The following is a description of a gene set: Adaptive Immune System Mouse Gene Set: REACTOME_ADAPTIVE_IMMUNE_SYSTEM studied in species Mus musculus, and this is the list of marker genes: Cd300c, Calr (calreticulin), Cd40, Stim1, Psmd11, H2-M10.2, Pak1, Psma4 (NCBI Gene Id 26441), Cd274, H2-DMa, Psmd6, Igkv2-137, Spsb1, Smurf2, Klc4, Kif13b, Kif3c, Ube3c, Rela, Treml1, Kif1c, Npdc1, Ppl, Ubr1, Fbxl13, Plcg2, Hecw2, Pik3cd, Tubb6, Tapbp, Lat, Icam5 (NCBI Gene Id 15898), Rnf138 (NCBI Gene Id 80618), Psmd13, Igll1, Kif21b, Ighv6-6, Siah1a, Rnf6, Ighv5-17, Igkv1-117, Rbck1, Herc4, H2-M10.4, Itgb2, Hectd3, Klhl41, Ptpn6, Ighv12-3, H2-M10.1, Psmd8, Psmc2, Prkcb, Cdc26, Inpp5d, Rbx1, Tuba1a, Trim71, Cul2, Crtam, Lrr1, Rlim (ring finger protein, LIM domain interacting), Psmc5, Rab7, Fbxl21, Kif2a, Ube2d3, Socs3, Fbxo6, Trbv15, Ighv5-9, Igkv1-132, Ccnf (NCBI Gene Id 12449), Fbxo7, Ppp3r1, Spsb4, Fbxo44, Cd300a, Actr1b, Nfkbib, Cxadr, Sec24d, Map3k8, Dtx3l, Rchy1, Klc3, Trim21, Ltn1, Ube3b, Ap2s1 (adaptor-related protein complex 2, sigma 1 subunit), Klhl21, Fbxo27, Ighv5-12-4, H2-M11, Psmb10, Cd226, Rnf213, Psmb3, Cd3g (NCBI Gene Id 12502), Asb5, Hspa5, Iglc2, H2-T10, Fbxw17, Kif9, Tuba1b, Raf1, Cdc20, Itpr1, Ighv8-2, Igkv1-99, Asb14, Fbxo22, Klrk1, Asb13, Asb9, Akt1, Adrm1, Ppp3cb, Ctss, Psmb8, Siglech, Cd81, Csk, Vhl, Pik3r6, Lrsam1, Fkbp1a, Clta, Tyrobp, Kif3a, Klhl25, Actr1a (NCBI Gene Id 54130), Cd22, Klhl22, Osbpl1a, Igkv1-110, Siglec1, Psma6, Psma5, Ifitm1, Ighv3-6, Map3k14, Ighv8-8, Sec31a, Trav19, Dctn4, Rnf220, Ncf1, Spsb2 (NCBI Gene Id 14794), Psme2, Anapc1, Rnf126, Cd79a, Keap1, Mrc2, Mapkap1, Pten, Map3k7, Kif23, Klhl20, Potefam3d, Fbxo10, H2-M3, Mylip, Ap1g1 (NCBI Gene Id 52301), Ighv6-3, Asb10, Kir3dl1, Atg7, Traf7, Xdh, Fyn, Grb2, Tubal3, Sec22b, Psme2b, Them4, Ctsd, Psmd2 (NCBI Gene Id 77434), Ctso (NCBI Gene Id 99547), Kif19a, Fbxl14, Tubb2a, Ctsf, Igkv20-101-2, Ctsb, Ighv8-11, H2-Q7, Ap2m1, Ighv6-4, Btnl9, Itgb1, Psmb7, Asb4, Siglece, Kif20b, Prkaca, Cdc42, Ap1m1, Lmo7, Ap1b1, Pdcd1, Cybb, Traf6, Unkl, Herc1, Cd101, Asb18, Ppp2r1a, Asb16, Rapgef4, Anapc13, Hace1, Asb6, Ube2v2, Psmd14, Igkv18-36, Mkrn1, Igkv1-122, Igkv2-112, Col3a1, Fbxo31, Tuba8, Igkv8-21, Card11, Itk, Kif1a, Ncf4, Trim32, Psmc3, Trim41, Btnl2 (NCBI Gene Id 632007), Ubox5, Wsb1, Ptpn22, Calm2 (calmodulin 2), H2-Ea, Klhl11, Bcap31, Mib2, Fbxo17, Igkv1-135, Btbd1, Ube2s, Yes1, Lcp2, Rel, Huwe1, Cul1, Tubb2b, Pja1, Ap2a2, Btn2a2, H2-K1, Lyn, Ighv5-2, Pja2, Lnpep, Rasgrp1, Ppp2r5b, Kctd6, Kbtbd7, Rap1b (NCBI Gene Id 72733), Raet1e, Asb12, Ifi30, Igkv1-35, Lgmn, Sos1, Fbxl8 (NCBI Gene Id 50788), Trac, Fbxo9, Dynll1, Asb17, Treml2, Ubc, Cul3, Ube2e3, Ube2b, Potefam3c (NCBI Gene Id 670593), Pdcd1lg2, Fzr1, Rap1a, Rap1gap, Ighv5-9-1, Cd96, Rbbp6, Jaml, Socs1, Kif5b, Dctn1, Ppp2ca, Igkv17-121, Dapp1, Tap1, Cd207, Calm1, Arel1 (apoptosis resistant E3 ubiquitin protein ligase 1), Ube2w, Fbxw9, Kif21a, Icam4, H2-Eb2, Fbxo32, Capza2, Sptbn2, Psma1, Dync1i2, Rnf4, Itgb7, Lair1, Prkn, Fbxl19, Ube2j1, Gan, Ap1m2, Fbxo2, Fyb1, Cul7, Itpr3, Anapc5, Psmc1, Klhl2, H2-Q2, Ighv3-3, Cd8b1, Ctla4, Dync1li1, Kras, Kctd7 (potassium channel tetramerisation domain containing 7), Cd300lb, Fbxo4, Dynll2, Rac1, Kif28, Ighv8-13, H2-T22, Rapgef3, Ifitm3, Cd300e, Fbxw5, Tuba3a, Mrc1, Ap2a1, Rnf19a, Ap1s2, Uba7, Sftpd, Kif3b, Psma3, Anapc11, Rnf111, Ighv7-3, Ppp3ca, Trem2, Col2a1, Ikbkb, Tab2, Fbxw10, Akt3, Ctsl, Zap70, Cd8a, Trim69, Kif11, Ighv5-12, Anapc4, Blnk, Thop1, Vcam1, H2-M10.3, Prkcq, Psma2, Traip, Rnf130, Erap1, Ube2l3, Fbxw2, Igkv16-104 (immunoglobulin kappa variable 16-104), Ppp2r5c, Pvr, Pik3r1, Pik3r2, Kifc1, Dctn3, Cd86, Trim36, Pik3ap1, Col17a1, Col1a1, Psmb2, Ubr2, Ighd, H2-M5, Ptprc (protein tyrosine phosphatase receptor type C), Icam2, Ap1s1, Canx, Ripk2, Kif2b, Kif6, Ppp2r5a, Asb11, Vamp8, Trem1, Ube2d2a (ubiquitin-conjugating enzyme E2D 2A), Trbv16, Pik3r5, Igkv1-88, Dnm2, Ube2e1, Psma7, Cd160, Znrf1, Ube2c, Cd19, Eloc, Nfkb1, Trim50, Snap23, Lck, Tap2, Psme1, Rnf144b, Fbxo40, Cd33 (CD33 molecule), Ap1s3, H2-M2, Ywhab, Fbxw11, Pag1, Pik3ca, Madcam1, Kif12, Trpc1, Dzip3, Siah2, Igkv11-125, Akt2, Ube2h, Fbxl3, Fbxl7, Rnf182, Pik3cg, Ube3d, Cd80, Kif26b, Rps27a, Ube2e2, Ctsk, Ube2g1, Igkv2-109, Cdc27, Trat1, Rnf25, Dync1i1, H2-Eb1, Trim9, Fcgr4, BC051665, Fbxo15 (NCBI Gene Id 50764), Mgrn1, Ighv3-5, Psmb1, Nfatc2, Icos, H2-Q6, Fbxw4, Uba52, Sipa1, Ubac1, Klc2, Itgal, Skp2, H2-Q4, H2-T23, H2-DMb2, Ikbkg, Kif16b, Fbxl16, Igkv1-131, Klhl3, Src, Ppp2r5d, Malt1, Psmd1, Ube2v1, Fbxo30, Nck1 (NCBI Gene Id 319390), Cdc23, Nedd4, Cd34, Anapc2, Kif15, Ywhaz, Ptpn11, Kifc2 (NCBI Gene Id 223662), Siglecf, Oscar, Rnf115, Icosl, H2-M10.5, Trip12, Sec23a, Ctsc, Lonrf1, Racgap1, Cd1d1, Cd79b, Dctn2, Ighv5-6, Col1a2 (collagen, type I, alpha 2), Cbll1, Kif1b, Ighv16-1 (immunoglobulin heavy variable 16-1), Ufl1, Pak3, Ube2q2, Pilra, Sec24a, H2-Oa, Iglc1, Cd200, Ube2k, Grap2, Ighv3-4, Smurf1, Tubb3, Cd36, Bcl10, Npepps (NCBI Gene Id 97764), Cd3e, Tuba4a, Slamf7, Asb8, Cd300lg, Capzb, Ctse, Cenpe, Uba52rt (NCBI Gene Id 676687), Dcaf1, Btbd6, Ighv3-8, H2-DMb1, Ppp2cb, Plcg1, Rnf7, Siglecg, Fcgr1, Arf1, Ighv7-4, Clec4g, Sec24b, Igkv1-133, Fcgr3, Kif22, Pik3r3, Kif4, Herc2, Tubb4b, Det1 (NCBI Gene Id 76375), Sec13, Ube2j2, Rnf14, Fbxl4, Ighv3-1, Itpr2, H2-M10.6, Nfatc1, Ighv5-15, Calm3, Ctsh, Kif18b, Ighv8-9, Ighv8-6 (NCBI Gene Id 629930), Sh3kbp1, Uba1, Rnf19b, Cd40lg (NCBI Gene Id 21947), H2-Ab1, Actr10, Fbxl20, Fbxo11, Cltc, Kif20a (kinesin family member 20A), Tubb4a, Cblb, Rictor, Hras, Ppp2r1b, B2m, Klhl42, Blmh (bleomycin hydrolase), Fbxl5, Vamp3, Uba3, Dync1li2, Pak2, Nedd4l, Kbtbd13, Fbxl12, Fbxo21, Kif18a, Kif2c, Rnf41, Ighv6-7, Hectd2, Ppp2r5e, Ighv8-5, Sell, Trib3, Cyba, Ube2m, Herc6, Ighv6-5, Cd209a, Arih2, Ifitm2, Kif27, Lag3, Ube4a, Cd200r2, Rasgrp2, Ube2f, Psmc4, Kif5a, Pdpk1, H2-Ob, Cd3d, Fbxl15, Rasgrp3, Dnm3, Lnx1, Pdia3, Dnm1, Uba6, Lrrc41, Ube3a, Anapc10, Klhl5, Uba5, Ube2r2, Rnf114 (ring finger protein 114), Herc3, Trav16, Ubr4, Kbtbd8, Glmn, Znrf2, Ube2n, Sar1b, Sh3rf1, Fbxl18, Ighv5-4, Prkg1, Trim37, Ighv8-4, Igkv15-103, Slamf6, Vav1, Rilp, Nfatc3, Btk, Sec24c, Asb1, Chuk, Cd4, Kifap3, Treml4, Pik3cb, H2-Q10, Fcgr2b, Psmd12, Tnfrsf14, Fbxo41, Tuba3b, Ubb, Tubb1, Cdc16, Cd28, Hectd1, Klc1, Skp1, Ifitm6, H2-M9 (NCBI Gene Id 14997), Mlst8, Ube2q1, Ube2o, Psmd7, Asb7, Hcst, H2-Q1, Ighv8-12, Dync1h1, Ube2d1, Rnf34, Ighv7-2, Klhl13, Rnf217, Psmb5, Kif26a, Trim11 (NCBI Gene Id 94091), Kifc5b, Ptprj, Tuba1c, Psmc6, Prkacb, Stx4a, Cd74, Pianp, Btn1a1, Rap1gap2, Klhl9, Sh3gl2, Itga4, Ncf2, Elob, Prr5, Wwp1, Mtor, Ap2b1, Psmb6, Stub1, C3, Cd300c2, Ube2a, Ube2z, Dctn5, Nectin2, Psmb4, Ctsa (cathepsin A), Ube2l6, H2-Aa, Icam1, Mex3c, Ube2g2, Itch (NCBI Gene Id 77732), Anapc7, Trim39 (NCBI Gene Id 79263), Cdc34, Fbxw7, Dctn6, Psmd3, Capza3, Kir3dl2, Fbxw8, Ighv5-16, Nfkbia, Ifitm7, H2-M1, Rnf123, Syk, Itgav, Cd247, Ighv13-2, Tpp2